Given this list of marker genes Slc25a31, Abcc4, Adcy10, Slc25a51, Lrrc8c, Lrrc8d, Lrrc8a, Slc25a24, Slc46a2, Slc35b3, Slc25a32, Slc17a9, Lrrc8e, Slc25a17, Slc25a23, Slc25a4, Slc19a1, Slc25a41, Slc25a36, Lrrc8b (NCBI Gene Id 97282), Slc25a5, Shoc2, Slc25a47, Slc25a33, Slc35b2, here is a description of the gene set: The directed movement of nucleotide across a membrane. studied in species Mus musculus Mouse Gene Set: GOBP_NUCLEOTIDE_TRANSMEMBRANE_TRANSPORT